Given this list of marker genes Gpld1, Adora1, Mef2c, Src, Plek, Igbp1, Mtmr9, Bmp2, Chp2, Rock1, Ifng, Ppargc1b, Npnt, Ripk3, here is a description of the gene set: Any process that activates or increases the frequency, rate or extent of removal of phosphate groups from a molecule. studied in species Mus musculus Mouse Gene Set: GOBP_POSITIVE_REGULATION_OF_DEPHOSPHORYLATION